Given this list of marker genes H2AC18, DNMT3L (NCBI Gene Id 29947), H3C13, H2BC11, H2AB1, H3C6, H4C5, H2BC12L, H2BC15, H2BC13, H4C4, H2AC8, DNMT1, H2BC12, H3C8, H2BC4, H4C12 (NCBI Gene Id 8362), H2AC14, H2BC9, H4C9, H2BC14, H2BC6, H2AC7, H4C6, H3C2, H3C7, H2BC8, H3C10 (NCBI Gene Id 8357), H4C1, H2BC5, H3C15, H4C15, H2AC19, DNMT3B, UHRF1, H3-3B, H3C4, H4C2, H4C11, H2AC20, H3C11, H4C3, H3-3A, H3C14, H2BC26, H2AC6, H2BC21, H2AC4, H4C14, H3C1, H2AJ, H4C13, H3C12, H2BC1, H4C8, H2AZ2, H3C3, H2BC10, H4C16, H2BC7, H2BC3, DNMT3A, H2AX, H2BC17, here is a description of the gene set: Human Gene Set: REACTOME_DNA_METHYLATION studied in species Homo sapiens DNA methylation